Given this list of marker genes Rnf115, Ptpn23, Vps37c, Chmp4b, Vps4a, Chmp2a, Chmp2b, Chmp4c, Chmp1b2, Plaa, Tsg101, Nedd4, Vps36, Vps28, Vps25, Chmp1b, Chmp6, Stam, Rnf126, Chmp7, Vps4b, Chmp5, Vps37b, Chmp1a, Chmp3, Ubap1, Vps37d, Ubap1l, Hdac6, Snf8, Vps37a (vacuolar protein sorting 37A), here is a description of the gene set: The chemical reactions and pathways resulting in the breakdown of a protein or peptide covalently tagged with ubiquitin, via the multivesicular body (MVB) sorting pathway; ubiquitin-tagged proteins are sorted into MVBs, and delivered to a lysosome/vacuole for degradation. Mouse Gene Set: GOBP_UBIQUITIN_DEPENDENT_PROTEIN_CATABOLIC_PROCESS_VIA_THE_MULTIVESICULAR_BODY_SORTING_PATHWAY studied in species Mus musculus